The following is a description of a gene set: Genes co-regulated in uterus during a time course response to progesterone: SOM cluster 2. species: Mus musculus from publication Yao MW, Lim H, Schust DJ, Choe SE, Farago A, Ding Y, Michaud S, Church GM, Maas RL (PMID 12554760) Mouse Gene Set: YAO_TEMPORAL_RESPONSE_TO_PROGESTERONE_CLUSTER_2 Human infertility and recurrent pregnancy loss caused by implantation defects are poorly understood. Hoxa-10-deficient female mice have severe infertility and recurrent pregnancy loss due to defective uterine implantation. Gene expression profiling experiments reveal that Hoxa-10 is an important regulator of two critical events in implantation: stromal cell proliferation and local immunosuppression. At the time of implantation, Hoxa-10 mediates the progesterone-stimulated proliferation of uterine stromal cells. Hoxa-10 mutants express a stromal cell proliferation defect that is accompanied by quantitative or spatial alterations in the expression of two cyclin-dependent kinase inhibitor genes, p57 and p15. Hoxa-10 deficiency also leads to a severe local immunological disturbance, characterized by a polyclonal proliferation of T cells, that occurs in place of the normal progesterone-mediated immunosuppression in the periimplantation uterus., and this is the list of marker genes: Clk1, Ccl27a, Ubap2l, Gcnt2, Rpp30, Capn3, Srsf7, Gnao1, Dtd2, Krtdap, Pklr (pyruvate kinase liver and red blood cell), Eln, Tnxb, Rab14 (RAB14, member RAS oncogene family), Smyd1, Aass, Sox3, Ogt, Prss58, Klrg1, Akap9, Prss39, Tardbp, Slc4a1, Etl4, Mmp12, Ttc14, Nptx1, Cdon, Clk4, Cyp1a2, Nmu, Apoa5, Fos, Epb41l4b, Bcl2, Pik3cd, Nr0b1, Ccnl2, Thbs2, Tiparp, Errfi1, Mylpf, Sox5, Meg3, Hgd, Rbm39, Zmym6, Sh3rf1, Nat8f1, Tacr2, Esr1, Hnrnpu, Paxbp1, Pla2r1, Fubp1, Cyp4a14, Napb